Given this list of marker genes ADAM17, TNFRSF1A, MMP8, TNFRSF1B, TMC8 (NCBI Gene Id 147138), TRAF2, A2M, here is a description of the gene set: Binding to tumor necrosis factor, a proinflammatory cytokine produced by monocytes and macrophages. Human Gene Set: GOMF_TUMOR_NECROSIS_FACTOR_BINDING studied in species Homo sapiens